The following is a description of a gene set: Human Gene Set: HP_GAZE_EVOKED_NYSTAGMUS studied in species Homo sapiens Gaze-evoked nystagmus Nystagmus made apparent by looking to the right or to the left., and this is the list of marker genes: GRM1, SACS, KCND3, ATXN1, ATXN3, SYT14, UBAP1, RFC1, THG1L, SDHA, SLC1A3, COQ2, UROC1, SPG11, GRID2, SCN8A, ATXN2, PRKCG (NCBI Gene Id 57013), VPS13D, BEAN1, FGF14 (fibroblast growth factor 14), POLR3B, TDP1, MRE11, EXOSC9, CACNA1G, SOX3, STUB1, ITPR1, TBP, ATP1A2, PIK3R5, SETX, WWOX, UCHL1, PRDX3, PMPCA, SCN1A, PRRT2, GCH1, CACNA1A, SPTBN2, COL18A1, POLG, RBL2, ATXN10, GDAP2, TMEM106B, AFG3L2, VLDLR, POLR3A, CACNB4 (calcium voltage-gated channel auxiliary subunit beta 4), APTX, SAMD9L, PAX7